The following is a description of a gene set: Mouse Gene Set: MIR_5129_5P Genes predicted to be targets of miRBase v22 microRNA mmu_miR_5129_5p in miRDB v6.0 with MirTarget v4 prediction scores > 80 (high confidence targets). species: Mus musculus from publication Chen Y, Wang X (PMID 31504780), and this is the list of marker genes: Mybl2, Amd2, Ankrd10, 1700001O22Rik, Csmd2, 2210016L21Rik, Jade1, Phf12, Ripor1, Erf, Hdac4, Tnfsf4, Pax6, Tmem59l, Aar2, Il5, Mylip, Slc7a11, Hcfc1r1, Vsnl1, Dnaja2, Gfap, Cd37, Msn, Syndig1l, Wbp1l, Reg3g, Phf13, Nptx2, Heyl, Irf3, Cd33, Trappc3, Pacrg, Ogfod1, Frmd4b, 3110082J24Rik, Camk4, Trim35, Os9, Trim43b, Strip2, Eif3j2, Pramel60, Unc5b, Sox13, Cyp26b1, Pde1c, Plekhh1, Padi3, Ntsr1, Setd5, Rras, Ttyh3, Sorcs2